The following is a description of a gene set: species: Mus musculus from publication Yamazaki K, Aso T, Ohnishi Y, Ohno M, Tamura K, Shuin T, Kitajima S, Nakabeppu Y (PMID 12604609) Mouse Gene Set: YAMAZAKI_TCEB3_TARGETS_UP Genes up-regulated in embryonic stem cells from TCEB3 knockout mice. Elongin A is a transcription elongation factor that increases the overall rate of mRNA chain elongation by RNA polymerase II. To investigate the function of Elongin A in vivo, the two alleles of the Elongin A gene have been disrupted by homologous recombination in murine embryonic stem (ES) cells. The Elongin A-deficient ES cells are viable, but show a slow growth phenotype because they undergo a delayed mitosis. The cDNA microarray and RNase protection assay using the wild-type and Elongin A-deficient ES cells indicate that the expression of only a small subset of genes is affected in the mutant cells. Taken together, our results suggest that Elongin A regulates transcription of a subset but not all of genes and reveal a linkage between Elongin A function and cell cycle progression., and this is the list of marker genes: Fdx1, Clu, Ganab, Lmbrd1, Cul1, Fhod3, Sox17, Epas1, Col4a2, Gns, Arf4, Prpf38b, Plat, Lpp, Sema6a, Gnas, Caskin2, Stra6, Ptpn9, Ccnc, Cdc42ep1, Efemp2, Creb3l1, Tfpi, Tst, Pdia3, Spink1, P4ha1, Mpzl2, Cdh5, Psph, Ddah1, Ankrd50, Susd2, Xlr, Timp3, Srprb, Ext1, Serpinh1, Pga5, Nr4a1, Tnfrsf10b, Grem2, Clic1, Fndc3a, Itgb1, Nr2f2, Ramp2, Slc7a1, Surf4, Dyrk2, Entrep1, Nid1, App, Serping1, Ggta1, Gng10, Vegfa, Pxdn, Lgmn, Ccnd2, Mfge8, Fkbp9, Aqp8, Atp1b1, Zfhx3, Lamc1, Kit (NCBI Gene Id 16590), Kalrn, Spock1, Ypel2, Lama1, Hs3st1, Kdelr3, Igfbp4, Herpud1, Amfr, Wars1, Fut8, Stard10, Glul, Flrt3 (fibronectin leucine rich transmembrane protein 3), Enpep, Msl3, Tlnrd1, F3, Dock9, Cyb561a3 (NCBI Gene Id 76431), Rrbp1, Calm1, Thbd, Sparc, Rcor1, Col4a1, Atp6ap1, Ephb4, Tyro3, Ptprm, Ints6l, Myl3, Sfmbt2, Slc16a1, Fbxl22 (F-box and leucine-rich repeat protein 22), B2m, Hspg2, P4ha2, Ctsz, Vamp8, Plod1, Pde1b, Cst3, Cited2, Furin, Rnf24, Mdfic, Slc38a1, Gata6 (NCBI Gene Id 14465), Grina, Tcf7l2, Col4a5, Epop, Jund, P4hb, Lrpap1, Cd38, Lamb1, Cited1, Cryab, Srgn, Cdc42se2, Fbln2, Erp44, Ccn1, Calu, Zyx, Parvb, Psap, Rcn1, Bach1, Myh6, Nid2, Kdelr2, Gna12, Zfp644, Man1a2 (NCBI Gene Id 99756), Id2, Snai1, Sema6d, Tmed2, Ube2q2 (ubiquitin-conjugating enzyme E2Q family member 2), Sgce, Hoxc6, Mbnl2, Zfp871, Ctsl, Ttr, Cyp26a1, B4galnt2, Amotl2, Tcerg1, Ghr, Yaf2 (YY1 associated factor 2), Anxa2, Plod2, Hsdl1 (NCBI Gene Id 72552), Galnt2, Cobll1, Pth1r